Given this list of marker genes KIF11, ABHD2, PLP2, LGALS1, FAM149A, ITGB7, H2AC21, ARHGEF9, NUP210, FMNL1, HMGN3, MIR539, RALGAPA1, TBC1D8, KMO, CXXC1, LIG1, HMGB1 (NCBI Gene Id 3146), GPS2, MOB3A, CTPS1, ANP32B, NCAPD3, CST3, AP1S3, DDX46 (DEAD-box helicase 46), CCND3, DPP4 (dipeptidyl peptidase 4), NCAPG, ZDBF2, CLDN1, GEN1, GTF3C6, TRABD, ACTN1, DOCK5 (dedicator of cytokinesis 5), CTBP1 (C-terminal binding protein 1), MRPS15, PLAC8, PLAAT3, SETD7, DPY19L1, NAAA, PPM1M, PSMB1, PARVG, GPR68, KIT, H4C14, TOPBP1, FKBP5, POMP, NFX1, BRI3BP, H2AC15, CDK14, IARS1, XCR1, S100A4, RAD54L, FFAR2, H4C4, METTL2B, FLT3, UTRN, ARFGEF1, KDM5A, GNB4, EIF4G1, SUV39H1, RTN4IP1, TNNI2, UBTFL1, POU2F1, FGFR1, MSH2, PDIK1L, MCM7, HDAC1, TRIM59, CETN3 (centrin 3), ADCY6, SRGAP3, CLEC2L (C-type lectin domain family 2 member L), RAB27A, ESYT1, HMGN1, GRAMD1C, MACROH2A1, NUCKS1, DSCC1, WDFY4, ITPR1, TMSB10, CRIP1, MCM6, BIRC5, POLE, BTLA, CKB, OSBPL3, MRPL11, DNAJC9, GPR33, CBFA2T3, RBM3, ITGAE, CASP3, SEMA7A, LARS1 (leucyl-tRNA synthetase 1), POLR1A, CDV3, SLK, MICAL1, DUSP10, QPCT, TOP2A, SEPTIN6, TUBA1A, POLD1, CCDC88A, CYB561A3, RFX7, CLSPN (NCBI Gene Id 63967), PRKAB2, FFAR4, SLC33A1, RABGAP1L, CDKN3 (NCBI Gene Id 1033), AURKAIP1 (aurora kinase A interacting protein 1), PA2G4, LY75, FADS2, CENPE, RPL4 (ribosomal protein L4), SMC4, AKT3, NCOA7, MTHFD1, STRIP2, MAP4K1, PRKD3, CKS1B, PSMB8, FBXO45, KNL1, CEP43, TBRG1, RRM1, SINHCAF (NCBI Gene Id 58516), CHEK1, FUS, CYFIP2, NEMP2, MDH2, LRBA, CACNB3, LRRK2, CLEC9A, KLRK1, YBX3, FNBP1, UVRAG (NCBI Gene Id 7405), POLR3C, F2RL2, CDC42EP3, RIN3, TMEM150C, ARSB, KIF15 (NCBI Gene Id 56992), KLRD1, INO80, PTK2, EZH2, IL22RA2, ERH, MCM5, CD24, ALYREF, POLR2M, GLRX2, MNS1, MRPS14, RBBP7, here is a description of the gene set: Dendritic cells (DCs) process and present self and foreign antigens to induce tolerance or immunity. In vitro models suggest that induction of immunity is controlled by regulating the presentation of antigen, but little is known about how DCs control antigen presentation in vivo. To examine antigen processing and presentation in vivo we specifically targeted antigens to the two major subsets of DCs using chimeric monoclonal antibodies. Unlike CD8+ DCs that express the cell surface protein CD205, CD8- DCs, which are positive for the 33D1 antigen, are specialized for presentation on MHC class II. This difference in antigen processing is intrinsic to the DC subsets and associated with increased expression of proteins associated with MHC processing. studied in species Homo sapiens Genes up-regulated in splenic CD 33D1+ dendritic cells versus CD4 T cells. from publication Dudziak D, Kamphorst AO, Heidkamp GF, Buchholz VR, Trumpfheller C, Yamazaki S, Cheong C, Liu K, Lee HW, Park CG, Steinman RM, Nussenzweig MC (PMID 17204652) Human Gene Set: GSE6259_33D1_POS_DC_VS_CD4_TCELL_UP